Given this list of marker genes Pik3cg, Crkl, Pik3r5, Lyn, Epor, Pik3cb, Irs2, Pik3cd, Vav1, Gab1, Jak2, Pik3ca, Rapgef1, Grb2, Epo, Shc1, Pik3r1, here is a description of the gene set: Mouse Gene Set: REACTOME_SIGNALING_BY_ERYTHROPOIETIN studied in species Mus musculus Signaling by Erythropoietin